Given this list of marker genes TLR1, CRNKL1, NR4A1, ZNF189, PMEPA1, SNAPC1, BBS12, MIR17HG, ZNF227 (zinc finger protein 227), CISH, IL2, PFKFB3, TP53RK, ZNRD2-DT, THUMPD3-AS1, RIF1, LAX1, PPM1D, HSD17B7 (NCBI Gene Id 63064), PRPF38A, E2F6, SLC25A32, MED19, ADO, NCBP1, C8orf76, ZNF322P1, EGR3, TEX10, KBTBD8, CKS2, ALKBH1, FADD, NAB1, TACR2, DNAJA2, TTC9C, SNHG3, GET1, KRT222, NR4A3 (nuclear receptor subfamily 4 group A member 3), NPC1, USH2A, HNF4G, FBXO30, IL23A, BCL10, GPR183, ZNF165, KLF10, LCE2B, S1PR1 (sphingosine-1-phosphate receptor 1), SDF2, CTSL (cathepsin L), SH2D2A, KCTD21, IRF4, CREM, TRMT10C, UMPS, TNFSF14, TMEM165, ZNF230, ZSWIM3, RRAS2, ZNF879, ZNF587, LIF, MIR23AHG, LTA (lymphotoxin alpha), GPM6B, GEMIN6, PPAN, EXOSC3, TOLLIP, NAT1, MED18, TNFAIP8L2, PPIL1, NABP1, MIR21, RAB39B, NUBP1, BET1, ZNF436 (zinc finger protein 436), BCOR, CLDN1, CHAC2, MED21, ZNF267, EIF2B2, FBLN7, TXNDC15 (thioredoxin domain containing 15), MLYCD, PDSS1, SLC35F5, GPR18, EGR4, ZNF506, MBNL1-AS1, ZNF557, ZNF614, BAZ2B, GRAMD4, FAM177A1, SERPINC1 (NCBI Gene Id 462), GPATCH11, MRPL35 (mitochondrial ribosomal protein L35), RTP4, EGR1, MBTPS2, FAM98B (family with sequence similarity 98 member B), TNF, MYNN, PAN3-AS1, GIMAP1, WDR33, VTI1B, TRIM38, ZNF443, STX6, SNX16, MFAP1, LPAR6, MIR3142HG (MIR3142 host gene), EGR2, ZFP36L1, MLX, JAGN1, EPC2, RNF34, TMEM184C, LEO1, C1orf56 (NCBI Gene Id 54964), ATG101, POLR3D, KIAA1586, PPP1R10, ZNF200, ZPR1, C6orf120, DNAJB6, TAF5, TMEM223, S100A11, BTBD19, ERVH48-1, BCL2A1, TUBD1, ARL5B, EXOC2, RNF168, CD200, YIPF4, KDM6B, TRAPPC4, VMP1, SLC17A5, DUSP14, NAB2, CKAP2, IFIT3, CDC42EP1, ARHGEF5, ALG2, PHLDA1, MIR155HG, CD40LG, FBXO5 (F-box protein 5), GEM (GTP binding protein overexpressed in skeletal muscle), FYCO1, GLTPD2, AMMECR1L, PUS3, ZNF253, TSEN34, RABIF, TMEM88, SHISA2, SH3PXD2A, FNIP1, VPS33A, ZNF410, ELP5, GLB1, LCMT2, C14orf119, ANKRD37, NFKBID, HCP5, EVI2A, MFSD6, ZNF347, HAPSTR1, S1PR3, ARG2, here is a description of the gene set: Human Gene Set: GSE17974_CTRL_VS_ACT_IL4_AND_ANTI_IL12_1H_CD4_TCELL_DN from publication Elo LL, Järvenpää H, Tuomela S, Raghav S, Ahlfors H, Laurila K, Gupta B, Lund RJ, Tahvanainen J, Hawkins RD, Oresic M, Lähdesmäki H, Rasool O, Rao KV, Aittokallio T, Lahesmaa R (PMID 20620947) studied in species Homo sapiens The aim of this dataset was to study in detail the transcription kinetics initiated by cytokine IL-4 in early differentiation of Th2 cells. Genes down-regulated in comparison of untreated CD4 T cells at 0 h versus the cells treated with IL4 and anti-IL12 at 1 h.